The following is a description of a gene set: studied in species Homo sapiens Aspirin prevention of cancer metastasis Human Gene Set: WP_ASPIRIN_PREVENTION_OF_CANCER_METASTASIS, and this is the list of marker genes: TBXAS1, GNA13, GNA12, RHOA, TBXA2R, ARHGEF1, PTGS1